Given this list of marker genes GNB1, SLC24A1, PDE6G, GNAT1 (G protein subunit alpha transducin 1), GNGT1, PDE6B, SAG, CNGA1, RHO, CNGB1, PDE6A, here is a description of the gene set: studied in species Homo sapiens Human Gene Set: REACTOME_ACTIVATION_OF_THE_PHOTOTRANSDUCTION_CASCADE Activation of the phototransduction cascade